Given this list of marker genes TFRC, CPEB4, RUNDC3A, ERMAP, SLC7A5, TMCC2, ATG4D, ANK1, RIPOR3, XPO7, SPECC1, TBCEL, FBXO30, FHDC1, TRIM58, SPTA1, YPEL4, TRAK2, HECTD4, TFR2, ANKRD9, NATD1, ART4, LPIN2, here is a description of the gene set: Definitive erythroblast from publication He P, Lim K, Sun D, Pett JP, Jeng Q, Polanski K, Dong Z, Bolt L, Richardson L, Mamanova L, Dabrowska M, Wilbrey-Clark A, Madissoon E, Tuong ZK, Dann E, Suo C, Goh I, Yoshida M, Nikolić MZ, Janes SM, He X, Barker RA, Teichmann SA, Marioni JC, Meyer KB, Rawlins EL (PMID 36493756) species: Homo sapiens Human Gene Set: HE_LIM_SUN_FETAL_LUNG_C3_DEFINITIVE_ERYTHROBLAST